Given this list of marker genes GRIA1, GRIN2B, GRIN2A (NCBI Gene Id 2903), FLOT2, GRIN1, FLOT1, RTN3, PTPRD, DLG1, LRFN2, GRIN2C, PTPRF, DLG3, GRIN2D (glutamate ionotropic receptor NMDA type subunit 2D), LRFN4, GRIA3, LRFN1, GRIA4 (NCBI Gene Id 2893), PTPRS, LRFN3, DLG4, here is a description of the gene set: species: Homo sapiens Reactome Pathway: Synaptic adhesion-like molecules part of: Protein-protein interactions at synapses Recruitment of receptors and ion channels to the postsynaptic membrane is the last step in synapse formation. Many of these proteins interact directly or indirectly with postsynaptic density-95 (PSD95)/Discs large/zona occludens-1 (PDZ) proteins, thus linking them to the postsynaptic scaffold and providing a mechanism for both retaining the protein at the synapse and keeping its proximity to signaling molecules known to associate with PDZ proteins. The synaptic adhesion-like molecules (SALM) family belongs to the superfamily of leucine-rich repeat (LRR)-containing adhesion molecules, alternatively referred to as LRFN (leucine-rich repeat and fibronectin III domain-containing) is synapse adhesion molecule linked to NMDA and AMPA receptors. It includes five known members (SALMs 1-5 or LRFN1-5), which have been implicated in the regulation of neurite outgrowth and branching, and synapse formation and maturation. SALM proteins are distributed to both dendrites and axons in neurons. The family members, SALM1-SALM5, have a single transmembrane (TM) domain and contain extracellular leucine-rich repeats, an Ig C2 type domain, a fibronectin type III domain, and an intracellular postsynaptic density-95 (PSD-95)/Discs large/zona occludens-1 (PDZ) binding domain, which is present on all members except SALM4 and SALM5.